Given this list of marker genes PTK2, ITGA4, VAV2, MAPK6, ZYX, SHC1, CAV3, AKT3, BRAF, ITGAV, CAPNS1 (NCBI Gene Id 826), ITGA1, RAP1B, CAPN2, PXN, MAP2K1, CDC42, PAK1, MAPK12, SORBS1, SHC3, CAPN3, TNS1, MAP2K3, ITGAX, ITGA8, MAPK4, ITGA2B, ITGA5, VASP, SRC, CSK, FYN, RAP1A, DOCK1, AKT1, ITGB1, PAK6, CAV1, SOS1, ITGA9, RAC1, RAC2 (NCBI Gene Id 5880), BUB1B-PAK6, ILK, ARHGEF7, ITGB3, CAPN5, CAPN10, CAPN11, ITGB6, ITGAD, PAK3, MAPK10, ITGB8, RHO, CAPN1, RAC3, CAV2, MAP2K5, MYPN, ITGA10, VAV3, PAK2, TLN1, CAPN9, ITGB5, GIT2, ITGB4, ITGB7, ITGAE, ITGAM, ITGA3, MAP2K2, ITGA6, VCL, BCAR1, PIK3R2, MAPK1, ITGA7, MIR34C, PDPK1, ITGA2, ITGA11, ITGB2, HRAS (NCBI Gene Id 338029), CAPN7, ARAF, SELENOP, ROCK2, MYLK2, CAPN6, RAPGEF1, AKT2, ROCK1, MAP2K6, RAF1, CRK, ITGAL, PAK4, MAPK7, GRB2, here is a description of the gene set: Integrin-mediated cell adhesion studied in species Homo sapiens Human Gene Set: WP_INTEGRINMEDIATED_CELL_ADHESION